Given this list of marker genes DLGAP4, NXF1, ABCG1, RASGRP4, ZNF7, ICAM2, LDLRAD3, DUSP7, RFX3, PHF12, DUSP19, PAGR1, RWDD2A, ST8SIA6, CTDSP2, LRRC20, SS18L1 (NCBI Gene Id 26039), SRSF1, CREBL2, MXD4, TMC4, SLC35C2, RPL23A, TSNAX, RPS26, MBD6, XAF1, PIAS1, CD244, CITED2, JCHAIN, EHF, ITGA8, TRIM37, SCN2B, SPPL3, LINC01160, RAMP1, TCTA, FAM111A, C2CD5, NBEAL2, RNF114, APOBR, BCKDK (NCBI Gene Id 94996), LANCL1, RPS25, PTPN6, MED12, ARFGEF1, MCAT, SESN3, METTL18, PPP1R14A, GRAMD1C, TACC1, PDRG1, VPS26C, TP53INP1, SPIB, CD79B, RAB39A, BBS9, H2AJ, RTEL1, PAN2, R3HCC1, MRPL16, ZNF217 (NCBI Gene Id 7764), DESI2, ZNF229, EID1, ANXA6, NIPBL, KLC1, FXR1, SCAPER, NOP16, MEAK7, SMIM6, CEP162, HERC1, HNF1A, DEPTOR, PLEKHA5, SUMF1, E2F6, SAMD9L, ABCB10, HIPK2, DHX16, PRR12, RFESD, IP6K1, HES6, ZNF862, ZNRD2, FOXP1, CD5 (CD5 molecule), SETDB1, TMA7, FAM193B, OXLD1, POU2F2, INPP5F, PNKP, MAPK7, ZFP36L2, MAP3K3, STK10, PITHD1, ATG4C, TSC22D4, TSPYL4, JMJD4, SUPT4H1, GEMIN6, RAD1, GP2, PRKCZ, H2BC5, MARK2, SBK1, MPND, SNX21, ACTN1, OARD1, LRIG1, BAG4, RFC1, CHST15, CCDC91, WDR6, ATP8B2, PIGV, ARHGAP28, ZDHHC7, ZBTB6, CCDC28B, GUCD1, CLEC4M, ZNF710, SENP3, CCDC47, UPF2, ASB13, LIMD2, RAB32, RAPGEF1, ADGRA2, DAPP1, UBQLN1, SRPK1, AKT3, SH2D1B, CTU1, AFF3, AKNA, LIPT2, RCBTB1, SUSD3, CCDC102A, ZNF606, GEMIN8, USP6NL, ITGA4, ZNF398, ARGLU1, KDM3B (NCBI Gene Id 51780), CYRIA, KLHL24, TRIM65, EHBP1L1, DYNC1H1, CHRNB1, SLC25A23 (NCBI Gene Id 79085), SECTM1, TBC1D10C, ARHGEF1, NXPE4, KLF2, B4GALT4, FAM98C, REC114, ATAD5, NDUFAF3 (NADH:ubiquinone oxidoreductase complex assembly factor 3), KLHDC1, GSDMD, HEXD, RAP1GAP2, RPAP1, MX2, KLF11, NT5C, ESAM, BCL2L15, SMIM5, MAPK8IP3, FAM234B, NAPSA, here is a description of the gene set: Many symptoms associated with allergic asthma result from the sequelae of type 2 inflammation. Interleukin (IL)-25 promotes type 2 inflammatory responses, and T2M cells represent an IL-4 and IL-13 producing granulocytic IL-25 responsive population. We used microarrays to characterize the gene expression profile of T2M cells, and compared T2M cells to other inflammatory subsets (eosinophils, neutrophils, and macrophages) in the lungs of mice with IL-25-induced pulmonary inflammation. from publication Petersen BC, Budelsky AL, Baptist AP, Schaller MA, Lukacs NW (PMID 22543263) studied in species Homo sapiens Human Gene Set: GSE36392_MAC_VS_NEUTROPHIL_IL25_TREATED_LUNG_UP Genes up-regulated in comparison of macrophages treated with IL25 versus neutrophils treated with IL25.